Given this list of marker genes ETS1, SLC2A1, FXN, SP1, EGLN2, ELOB, CITED2, SLC11A2, FLT1, POU5F1, EPO, CREBBP, SIRT1 (sirtuin 1), HIF1AN, APEX1, TWIST1, EFNA1, ELK1, ABCG2, ELOC, EP300, MMP14, ADORA2A (NCBI Gene Id 135), VHL, PGK1, KDR, EIF3E, EGLN1, BHLHE40, EGLN3, SERPINE1, VEGFA, ARNT, EPAS1, here is a description of the gene set: Human Gene Set: PID_HIF2PATHWAY from publication Schaefer CF, Anthony K, Krupa S, Buchoff J, Day M, Hannay T, Buetow KH (PMID 18832364) species: Homo sapiens HIF-2-alpha transcription factor network